Given this list of marker genes SNRPB, TP63, NBN, FRAS1, RMRP, FERMT1, SALL1, HES7, DCHS1, MNX1, PITX2, CDH11 (NCBI Gene Id 1009), AMER1, SMO, FREM1, KAT6B, LIG4, KDM6A, FREM2, SALL4, CHD7, RIPK4, TBX3, FAT4, PIGN, GRIP1, PIGO, FOXC1, MED12 (mediator complex subunit 12), CDC45, KMT2D, CACNA1C, PGAP2, NSUN2, here is a description of the gene set: Anal stenosis species: Homo sapiens Abnormal narrowing of the anal opening. Human Gene Set: HP_ANAL_STENOSIS